The following is a description of a gene set: Any process that modulates the frequency, rate, or extent of cellular extravasation. species: Mus musculus Mouse Gene Set: GOBP_REGULATION_OF_CELLULAR_EXTRAVASATION, and this is the list of marker genes: Ripor2, Ptger3, Cd99l2 (NCBI Gene Id 56789), Pawr, Il1r1, Ccl28, Plvap, Abr, Ripk3, Sele, Cxcl12, Cd47, Chst2, Jam3, Fut4, Plcb1, Lyve1, Ccl25, Capn1, Med23, Ager, Fadd, Gp1ba (glycoprotein 1b, alpha polypeptide), Ccr2, Mdk (NCBI Gene Id 17242), Gcnt1, Ccl21e, Bcr, Itga4, Adam8, Pdgfd, Ccl21b, Elane, St3gal4, Ccl2, Icam1, Fut9, Ptger4, Ccl21f, Selp, Chst4, Pecam1, Ptafr (NCBI Gene Id 636551), Ccl21d, Thy1, Fut7, Il27ra, Ccl21a